The following is a description of a gene set: studied in species Homo sapiens Genes down-regulated in HT1080 (fibrosarcoma) cells by treatment with interferon beta for 6 h. Human Gene Set: DER_IFN_BETA_RESPONSE_DN from publication Der SD, Zhou A, Williams BR, Silverman RH (PMID 9861020) The pleiotropic activities of interferons (IFNs) are mediated primarily through the transcriptional regulation of many downstream effector genes. The mRNA profiles from IFN-alpha, -beta, or -gamma treatments of the human fibrosarcoma cell line, HT1080, were determined by using oligonucleotide arrays with probe sets corresponding to more than 6,800 human genes. Among these were transcripts for known IFN-stimulated genes (ISGs), the expression of which were consistent with previous studies in which the particular ISG was characterized as responsive to either Type I (alpha, beta) or Type II (gamma) IFNs, or both. Importantly, many novel IFN-stimulated genes were identified that were diverse in their known biological functions. For instance, several novel ISGs were identified that are implicated in apoptosis (including RAP46/Bag-1, phospholipid scramblase, and hypoxia inducible factor-1alpha). Furthermore, several IFN-repressed genes also were identified. These results demonstrate the usefulness of oligonucleotide arrays in monitoring mammalian gene expression on a broad and unprecedented scale. In particular, these findings provide insights into the basic mechanisms of IFN actions and ultimately may contribute to better therapeutic uses for IFNs., and this is the list of marker genes: SGSH, SLC30A3, TBCE, TRAF6, CHRNB2, ARHGAP4, PLPP3, IGF2